Given this list of marker genes NRAS, UBA52, PIK3R1, NRG3, ERBB4, CXCL12, KRAS, SOS1, S100B, EREG, ERBB3, GABRG3, NCSTN, EGFR, GABRA1, PSEN2, CSN2, EGF, GABRB2, SPARC, APH1B, PGR, WWOX, GFAP, ESR1, GABRB3, GABRG2, TAB2, APOE, STMN1, BTC (betacellulin), PSENEN, GABRB1, ADAM17, STAT5A, HBEGF, UBB, ADAP1, YAP1, NEDD4 (NCBI Gene Id 4734), ITCH, SRC, NRG4, MXD4, PSEN1, DLG4, PIK3CA, GRB2, NRG2, WWP1, NRG1, NCOR1, HRAS, UBC, SHC1, APH1A, RPS27A, GABRQ (gamma-aminobutyric acid type A receptor subunit theta), here is a description of the gene set: Reactome Pathway: Signaling by ERBB4 part of: Signaling by Receptor Tyrosine Kinases studied in species Homo sapiens ERBB4, also known as HER4, belongs to the ERBB family of receptors, which also includes ERBB1 (EGFR/HER1), ERBB2 (HER2/NEU) and ERBB3 (HER3). Similar to EGFR, ERBB4 has an extracellular ligand binding domain, a single transmembrane domain and a cytoplasmic domain which contains an active tyrosine kinase and a C-tail with multiple phosphorylation sites. At least three and possibly four splicing isoforms of ERBB4 exist that differ in their C-tail and/or the extracellular juxtamembrane regions: ERBB4 JM-A CYT1, ERBB4 JM-A CYT2 and ERBB4 JM-B CYT1 (the existence of ERBB4 JM-B CYT2 has not been confirmed). <br><br>ERBB4 becomes activated by binding one of its seven ligands, three of which, HB-EGF, epiregulin EPR and betacellulin BTC, are EGF-like, while four, NRG1, NRG2, NRG3 and NRG4, belong to the related neuregulin family. Upon ligand binding, ERBB4 forms homodimers or it heterodimerizes with ERBB2. Dimers of ERBB4 undergo trans-autophosphorylation on tyrosine residues in the C-tail, triggering downstream signaling cascades. The pathway Signaling by ERBB4 only shows signaling by ERBB4 homodimers. Signaling by heterodimers of ERBB4 and ERBB2 is shown in the pathway Signaling by ERBB2. Ligand-stimulated ERBB4 is also able to form heterodimers with ligand-stimulated EGFR and ligand-stimulated ERBB3. Dimers of ERBB4 with EGFR and dimers of ERBB4 with ERBB3 were demonstrated in mouse cell lines in which human ERBB4 and EGFR or ERBB3 were exogenously expressed. These heterodimers undergo trans-autophosphorylation. The promiscuous heteromerization of ERBBs adds combinatorial diversity to ERBB signaling processes. As ERBB4 binds more ligands than other ERBBs, but has restricted expression, ERBB4 expression channels responses to ERBB ligands. The signaling capabilities of the four receptors have been compared.<br><br>As for other receptor tyrosine kinases, ERBB4 signaling effectors are largely dictated through binding of effector proteins to ERBB4 peptides that are phosphorylated upon ligand binding. All splicing isoforms of ERBB4 possess two tyrosine residues in the C-tail that serve as docking sites for SHC1. Once bound to ERBB4, SHC1 becomes phosphorylated on tyrosine residues by the tyrosine kinase activity of ERBB4, which enables it to recruit the complex of GRB2 and SOS1, resulting in the guanyl-nucleotide exchange on RAS and activation of RAF and MAP kinase cascade. <br><br>The CYT1 isoforms of ERBB4 also possess a C-tail tyrosine residue that, upon trans-autophosphorylation, serves as a docking site for the p85 alpha subunit of PI3K, leading to assembly of an active PI3K complex that converts PIP2 to PIP3 and activates AKT signaling. <br><br>Besides signaling as a conventional transmembrane receptor kinase, ERBB4 differs from other ERBBs in that JM-A isoforms signal through efficient release of a soluble intracellular domain. Ligand activated homodimers of ERBB4 JM-A isoforms (ERBB4 JM-A CYT1 and ERBB4 JM-A CYT2) undergo proteolytic cleavage by ADAM17 (TACE) in the juxtamembrane region, resulting in shedding of the extracellular domain and formation of an 80 kDa membrane bound ERBB4 fragment known as ERBB4 m80. ERBB4 m80 undergoes further proteolytic cleavage, mediated by the gamma-secretase complex, which releases the soluble 80 kDa ERBB4 intracellular domain, known as ERBB4 s80 or E4ICD, into the cytosol. ERBB4 s80 is able to translocate to the nucleus, promote nuclear translocation of various transcription factors, and act as a transcription co-factor. For example, in mammary cells, ERBB4 binds SH2 transcription factor STAT5A. ERBB4 s80 shuttles STAT5A to the nucleus, and actsa as a STAT5A co-factor in binding to and promoting transcription from the beta-casein (CSN2) promoter, and may be involved in the regulation of other lactation-related genes. ERBB4 s80 binds activated estrogen receptor in the nucleus and acts as a transcriptional co-factor in promoting transcription of some estrogen-regulated genes, including progesterone receptor gene NR3C3 and CXCL12 (SDF1). In neuronal precursors, ERBB4 s80 binds the complex of TAB and NCOR1, helps to move the complex into the nucleus, and is a co-factor of TAB:NCOR1-mediated inhibition of expression of astrocyte differentiation genes GFAP and S100B.<br><br>The C-tail of ERBB4 possesses several WW-domain binding motifs (three in CYT1 isoform and two in CYT2 isoform), which enable interaction of ERBB4 with WW-domain containing proteins. ERBB4 s80, through WW-domain binding motifs, interacts with YAP1 transcription factor, a known proto-oncogene, and is a co-regulator of YAP1-mediated transcription in association with TEAD transcription factors. Hence, the WW binding motif couples ERBB4 to the major effector arm of the HIPPO signaling pathway. The tumor suppressor WWOX, another WW-domain containing protein, competes with YAP1 in binding to ERBB4 s80 and prevents translocation of ERBB4 s80 to the nucleus.<br><br>WW-domain binding motifs in the C-tail of ERBB4 play an important role in the downregulation of ERBB4 receptor signaling, enabling the interaction of intact ERBB4, ERBB4 m80 and ERBB4 s80 with NEDD4 family of E3 ubiquitin ligases WWP1 and ITCH. The interaction of WWP1 and ITCH with intact ERBB4 is independent of receptor activation and autophosphorylation. Binding of WWP1 and ITCH ubiquitin ligases leads to ubiquitination of ERBB4 and its cleavage products, and subsequent degradation through both proteasomal and lysosomal routes. In addition, the s80 cleavage product of ERBB4 JM-A CYT-1 isoform is the target of NEDD4 ubiquitin ligase. NEDD4 binds ERBB4 JM-A CYT-1 s80 (ERBB4jmAcyt1s80) through its PIK3R1 interaction site and mediates ERBB4jmAcyt1s80 ubiquitination, thereby decreasing the amount of ERBB4jmAcyt1s80 that reaches the nucleus.<br><br>ERBB4 also binds the E3 ubiquitin ligase MDM2, and inhibitor of p53. Other proteins that bind to ERBB4 intracellular domain have been identified by co-immunoprecipitation and mass spectrometry, and include transcriptional co-repressor TRIM28/KAP1, which promotes chromatin compaction. DNA damage signaling through ATM releases TRIM28-associated heterochromatinization. Interactions of ERBB4 with TRIM28 and MDM2 may be important for integration of growth factor responses and DNA damage responses.<br><br>In human breast cancer cell lines, ERBB4 activation enhances anchorage-independent colony formation in soft agar but inhibits cell growth in a monolayer culture. Different ERBB4 ligands induce different gene expression changes in breast cancer cell lines. Some of the genes induced in response to ERBB4 signaling in breast cancer cell lines are RAB2, EPS15R and GATA4. It is not known if these gene are direct transcriptional targets of ERBB4.<br><br>Transcriptome and ChIP-seq comparisons of full-length and intracellular domain isoforms in isogenic MCF10A mammary cell background have revealed the diversification of ERBB4 signaling engendered by alternative splicing and cleavage. ERBB4 broadly affected protease expression, cholesterol biosynthesis, HIF1-alpha signaling, and HIPPO signaling pathways, and other pathways were differentially activated by CYT1 and CYT2 isoforms. For example, CYT1 promoted expression of transcription factors TWIST1 and SNAIL1 that promote epithelial-mesenchymal transition. HIF1-alpha and HIPPO signaling are mediated, respectively, by binding of ERBB4 to HIF1-alpha and to YAP. ERBB4 increases activity of the transcription factor SREBF2, resulting in increased expression of SREBF2-target genes involved in cholesterol biosynthesis. The mechanism is not known and may involve facilitation of SREBF2 cleavage through ERBB4-mediated PI3K signaling.<br><br>In some contexts, ERBB4 promotes growth suppression or apoptosis. Activation of ERBB4 in breast cancer cell lines leads to JNK dependent increase in BRCA1 mRNA level and mitotic cell cycle delay, but the exact mechanism has not been elucidated (Muraoka Cook et al. 2006). The nature of growth responses may be connected with the spliced isoforms expressed. In comparisons of CYT1 vs CYT2 (full-length and ICD) expression in mammary cells, CYT1 was a weaker growth inducer, associated with attenuated MAPK signaling relative to CYT2. ERBB4 s80 is also able to translocate to the mitochondrial matrix, presumably when its nuclear translocation is inhibited. Once in the mitochondrion, the BH3 domain of ERBB4, characteristic of BCL2 family members, may enable it to act as a pro apoptotic factor.<br><br>ERBB4 plays important roles in the developing and adult nervous system. Erbb4 deficiency in somatostatin-expressing neurons of the thalamic reticular nucleus alters behaviors dependent on sensory selection. NRG1-activated ERBB4 signaling enhances AMPA receptor responses through PKC-dependent AMPA receptor exocytosis. This results in an increased excitatory input to parvalbumin-expressing inhibitory neurons in the visual cortex and regulates visual cortical plasticity. NRG1-activated ERBB4 signaling is involved in GABAergic activity in amygdala which mediates fear conditioning (fear memory). Conditional Erbb4 deletion from fast-spiking interneurons, chandelier and basket cells of the cerebral cortex leads to synaptic defects associated with increased locomotor activity and abnormal emotional, social and cognitive function that can be linked to some of the schizophrenia features. The level of GAD1 (GAD67) protein is reduced in the cortex of conditional Erbb4 mutants. GAD1 is a GABA synthesizing enzyme. Cortical mRNA levels of GAD67 are consistently decreased in schizophrenia (Del Pino et al. 2014). Erbb4 is expressed in the GABAergic neurons of the bed nucleus stria terminalis, a part of the extended amygdala. Inhibition of NRG1-triggered ERBB4 signaling induces anxiety-like behavior, which depends on GABAergic neurotransmission. NRG1-ERBB4 signaling stimulates presynaptic GABA release, but the exact mechanism is not known. NRG1 protects cortical interneurons against ischemic brain injury through ERBB4-mediated increase in GABAergic transmission. NRG2-activated ERBB4 can reduce the duration of GABAergic transmission by binding to GABA receptors at the postsynaptic membrane via their GABRA1 subunit and promoting endocytosis of GABA receptors. NRG1 promotes synchronization of prefrontal cortex interneurons in an ERBB4 dependent manner. NRG1-ERBB4 signaling protects neurons from the cell death induced by a mutant form of the amyloid precursor protein (APP).<br><br>Clinical relevance of ERBB4 has been identified in several contexts. In cancer, putative and validated gain-of-function mutations or gene amplification that may be drivers have been identified at modest frequencies, and may also contribute to resistance to EGFR and ERBB2-targeted therapies. This is noteworthy as ERBB4 kinase activity is inhibited by pan-ERBB tyrosine kinase inhibitors, including lapatinib, which is approved by the US FDA. The reduced prevalence relative to EGFR and ERBB2 in cancer may reflect more restricted expression of ERBB4, or differential signaling, as specific ERBB4 isoforms have been linked to growth inhibition or apoptosis in experimental systems. ERBB2/ERBB4 heterodimers protect cardiomyocytes, so reduced activity of ERBB4 in patients treated with the ERBB2-targeted therapeutic antibody trastuzumab may contribute to the cardiotoxicity of this agent when used in combination with (cardiotoxic) anthracyclines.<br><br>With the importance of ERBB4 in developing and adult nervous system, NRG1 and/or ERBB4 polymorphisms, splicing aberrations and mutations have been linked to nervous system disorders including schizophrenia and amyotrophic lateral sclerosis, although these findings are not yet definitive.